Given this list of marker genes PARP6, KLHL14, TLL2, AIF1L, KCNB1, VPS39, SH3GL2, CECR2, KCNIP1, CDIN1, KIF21B, PRMT6, STAB2, PIANP, SHOC1, SRGAP2, GOSR2, NFYA, SUSD6 (sushi domain containing 6), KIAA0513, SLC6A17, WDTC1, SLC10A7, USP7, RGMB, TENT4A, LSM12, ATP2B4, AK3, BAZ2A, TRIOBP, REG3G, STEAP2, TRIM26, ST3GAL5, PUM2 (NCBI Gene Id 23369), FAM53A, C17orf67, CHAF1A, WASF2, SOX10, IKZF1, DCX, SMARCD1, NQO1, ACVR2B, PPM1M, CIC, TRIM46, RHBDL1, TSPAN9, FAM78A, AGO1, COL16A1, XYLT1, KBTBD2, ZNF862, HLA-DOB, NOS1, TRIM4, TRIM35, N4BP1, NAV1, NRIP2, LDLRAP1, RNF19B, TCEA2, ERG28, COL5A3, ANKFY1, STK35, NEUROD4, AMOT, GABRA4 (NCBI Gene Id 2557), HNRNPR, RAB1B, CERS3, SCML1, ETV4, TMEM201, PAX5, DGKK, ADAMTS4, RTKN, SSR1, RIMS2, CLIC5, TMEM217, PRR32, DUSP13A, MAFG, NOTCH2, CDON, ANKRA2, CBX7, MORN5, FNDC3B, MAP3K11, FHL1, SATB1, SLC37A1, KCND1, YTHDF3, ARHGEF6, here is a description of the gene set: Genes predicted to be targets of miRBase v22 microRNA hsa-miR-4632-5p in miRDB v6.0 with MirTarget v4 prediction scores > 80 (high confidence targets). species: Homo sapiens from publication Chen Y, Wang X (PMID 31504780) Human Gene Set: MIR4632_5P